The following is a description of a gene set: Mouse Gene Set: REACTOME_TOLL_LIKE_RECEPTOR_4_TLR4_CASCADE Toll Like Receptor 4 (TLR4) Cascade studied in species Mus musculus, and this is the list of marker genes: Vrk3, Mapk7, Cul1, Traf3, Tab3, Rps6ka1, Dnm1, Ppp2r1a, Ube2d2a, Mapk3, Atf2, Tbk1, Nlrx1, Nfkbib, Nfkb1, Birc3, Alpk1, Tank, Map2k6, Ly96 (NCBI Gene Id 17087), Rps6ka2, Optn, Jun, App, Usp14, Ticam1, Casp8, Nod1, Tab2, Bpi, Map2k3, Ube2d1, Map3k7, Nkiras2, Itgb2, Irak1, Fbxw11, S100b, Ticam2, Nfkb2, Creb1, Mapk11, Uba52rt, Ppp2r5d, Sarm1, Irf7, Dusp7, Rela, Sftpa1, Cd180, Dnm3, Traf6, Cd14, Peli2, Dusp4, Irak2, Chuk, Ppp2cb, Peli3, Ppp2r1b, Tifa (TRAF-interacting protein with forkhead-associated domain), Ptpn11 (NCBI Gene Id 72646), Atf1, Peli1, Usp18, Lrrc14, Traf2, Ripk1, Dusp6, Tirap, Fadd, Map2k4, Mapkapk2, Ppp2ca, Mapk14, Tab1, Nfkbia, Lbp, Ube2v1, Nlrc5, Plcg2, Uba52, Ikbkg, Mapk1, Rps6ka3, Sftpd, Nod2, Ptpn4, Birc2, Fos, Ager, Irf3, Rps27a, Ubb, Mapk9, Dusp3, Rps6ka5, Map3k8, Mapk8, Map2k7, Tlr4, Hmgb1, Ubc, Nkiras1, Tnip2, Dnm2, Ripk2, Skp1, Ly86, Ube2d3, N4bp1, Mapkapk3, Itgam, Ikbkb, Mapk10, Ripk3, Ecsit, Ube2n, Ikbke